The following is a description of a gene set: studied in species Mus musculus Mouse Gene Set: GOCC_MEMBRANE_MICRODOMAIN A membrane region with a lipid composition that is distinct from that of the membrane regions that surround it., and this is the list of marker genes: Ikbkb, Cnr1, Src, Ms4a1, Rangrf, Chrnb2, Stx12, Serpinh1 (NCBI Gene Id 12407), Dll1, Arid3c, Lyn, Itln1, Nos3, Trpm8, Slc1a1, Ehd2, Fasl, Rtn4rl2, Ms4a2, Myo1d, Bmpr1a, Kif18a, Hspa1b, Arc, Erlin2, Smpd2, Ppt1, Cln6, Lypd11, Mlc1, Ptprc, Trem2, Rftn1, Stoml3, Cd55 (CD55 molecule, decay accelerating factor for complement), Trpc1, Gpc1, Lrrk2, Kirrel1, Rab5a, Nos1ap, Pi4k2a, Myof, Abcg2, Eno1b, Plpp3, Cbl (NCBI Gene Id 12402), Cdh1, Chrna7, Mag, Ezr, Slc2a1, Aqp1, Tfpi, Prkar1a (NCBI Gene Id 80472), Cacna1c, Hk1, Ms4a4a, Bves, Vdac2, Fyn, Zap70, Lypd6 (LY6/PLAUR domain containing 6), Hspa1a, Mall, Actb, Ptpn11, Ly6k, Slc2a4, Inpp5d, Sgca, Npc1, Plscr2, Adrb2, Dlc1, Kcnma1, Kcna3, Adam17, Adtrp, Ghsr, Kcnd3, Plpp1, Unc5a, Asah2, Atp1a1, Furin, Stoml1, Pag1, Atp1b1, Ahnak, Cblc, P2rx1, Hck, Stoml2, Glipr1l1, Efna5, S1pr1, Tsc2, Stim1, Grk2, Ctsd, Gnaq, Dapk3, Lcp2 (lymphocyte cytosolic protein 2), Capn2, Pdpn, Kdr, Cr1l, Baalc, Plvap, Cd19, Tubb5, Cav2, Bmpr2, Flot1, Slc9a1, Tnfrsf1b, Kcna5, Plscr1 (phospholipid scramblase 1), Grip1, Best1, Tex101, Cd44, Kcnd2, Cav3, Akap6 (A kinase anchor protein 6), Ephb1, Chp1, Olr1, Jak2, Rit2, Fyb2, Cacna1h, Tuba1a, Lrp8, Emp2, Plcg2, Ppp2ca, Cntnap2, Tlr2 (NCBI Gene Id 24088), Slc1a2, Atp5f1b, Ctsb, Psen1, Cxadr, Prkar2a, Sele, Lrp6, Egfr, Dmd, Tnfrsf1a, Podxl, Cd14, Slc22a6, Lamtor1, Calhm1 (NCBI Gene Id 546729), Ctnnd1, H2-D1, Fcer1a, Cblb, Adgrg1, Smurf2, Btk, Ppp2r1b, Cavin3, Erbb4, Cd4, Add2, Prom2, Fcer1g, Cavin2, Tpp1, Itgam, Il6st, Mme, Cavin4, Slc25a4, Tuba1c, Lrp4, Traf2, Dysf, Tlr6, Park7, Atp2b4, App, Ptgis, Chrna3, Gpm6b, F2r, Has2, Stx2, Hpse, Rtn4r (NCBI Gene Id 65079), Atp5f1a, Akap5, Adra1b, Nfam1 (Nfat activating molecule with ITAM motif 1), Cln3, Gab2, Efnb1, Slc39a6, Coro1c, Slc6a4, Myo1a, Clip3 (CAP-GLY domain containing linker protein 3), Synj2, Itgb2, Eno1, Gask1a, Ldlr, Gja1, Lypd4, Ldhb, Sulf1, Tlr1, Ptch1, Insr, Cd8a, Lamp2, Scn5a, Vcl, Pikfyve, Sdcbp, Adcyap1r1, Trpc4, Myadm, Thy1, Fas (Fas cell surface death receptor), Tnf, Arid3a, Rap2b, Myo1c, Anxa2, Dag1, Mapt, Adcy8, Eeig1, Tnfrsf10b, Adam1a (NCBI Gene Id 280668), Ntsr1, Atp1a2, Cdh13, Tgfbr2, Abcb4 (NCBI Gene Id 18670), Cd24a, Selplg, Orai1, Gp6 (glycoprotein 6 platelet), Slc25a5, Slc2a3, Ptgs2, Vdr, Flot2, Fxyd1, Adcy2, Cdh15, Lypd10, Prss8 (NCBI Gene Id 97375), Ctnna1, Slc6a3, Eno2, Kcne3, Mapk1, Card11, Mal2, Tgfbr1, Entpd1, Lat2, S100a10, Prkaca, Hmox1, Sorbs1, Cd55b, Cd177, Htr2a, Slc27a1, Pecam1, Bcl10, Hdac6, Abcg3, Neu3, Abca1, Drd1, Cd48, Pllp (plasma membrane proteolipid), Cav1, Tek, Gprc5b, Rtn4rl1, Kcnq1 (NCBI Gene Id 547397), Scarb1, Mdga1, Skap1, Mal, Tnr, Pld2, Tnfrsf11a, Cd79a, Cavin1, Cripto, Lipe, Angpt1, Icam1, Shh, Dpp4, Mapk3, Nos1 (nitric oxide synthase 1, neuronal), Irs1, Bst2, Pacsin2, Hyal2, Bace1, Dlg1, Itgb1, Cd36, Faim2, Ctnnb1, Rhoq, Atp1b3, Prtn3, Kcne1, Cdh2, Hmgb1, Plpp2, Pgk1, Adra1a, P2ry12, Prnp, Igf1r, Tuba1b, Vdac1, Spred1, Rgmb, Nphs2, Efhd2, Slc5a7, Adcy1, Stom, Unc5b, Gp2, Spam1, Itgb2l, Adam3, Cd244a, Smo, Lck